Given this list of marker genes STXBP1 (NCBI Gene Id 6812), ORC6, GJB6, DONSON, UBR7, LMX1B (NCBI Gene Id 4010), SOX9, RECQL4, PRMT7, GJB2, TBX4, ZSWIM6, ANAPC1, PITX1, CRELD1, here is a description of the gene set: Patellar hypoplasia Human Gene Set: HP_PATELLAR_HYPOPLASIA Underdevelopment of the patella. studied in species Homo sapiens